The following is a description of a gene set: Human Gene Set: HP_FLANK_PAIN An unpleasant sensation characterized by physical discomfort (such as pricking, throbbing, or aching) and perceived to originate in the flank. Flank pain species: Homo sapiens, and this is the list of marker genes: CALR, GANAB, DNAJB11, TBX18, TET2, IFT140, PKD2, BICC1, ALG5, MPL, APRT, PKD1, ALG9, JAK2